Given this list of marker genes REL, IL13, RELB, VAPA, CPEB4, LAT, CREM, PEBP1, MAOB, SFT2D1, NINJ1, GALC, COL9A2, ALS2, ALG13, PTGS1, MAT2A, RASSF5 (NCBI Gene Id 83593), RBM8A, CAPG (NCBI Gene Id 822), DUSP10, CDKN1A, PIGA, SLC18A2, PRNP, MIR4435-2HG, HSPA5, STK17B, SFPQ, OAZ2, SAMSN1, PDCL3, CSF1, OSBPL8, CATSPER1, SYTL2, NSMCE1, VMP1, RPL24, LRP4, MCTP1, MIR202HG, CRBN, TLE3, FCER1A, SCIN, TPSAB1, NME4, LGALS12, CLU, RGS1, ABCA1 (ATP binding cassette subfamily A member 1), VEGFA, SVIP, EIF5A, TNFRSF9, HIF1A, JUND, GADD45B, YWHAE, ANXA7, PRKX, DNAJB14, COX7A1, CTNNBL1, MACIR, HSD17B4, CAVIN2, HLTF (NCBI Gene Id 6596), GLUL, TMEM255B, AHR, PRDX6, UTS2, SRSF7, ZNF511, HPGDS, LMNA, DDX27, PRKCA, ENPP3, ADAM12, MYADM, STX11, DNAJB6, NEDD9, SVOPL (NCBI Gene Id 136306), SKIL, EIF5, HNRNPK, RBMX, TANK, GABPB1-IT1, CYCS, KMT2E, BACE2, LAX1, MRPL33, LMNB1, TESPA1, BHLHE40, EIF4A3, ELL2, ANXA1, SMIM3, SRSF5 (serine and arginine rich splicing factor 5), CD82, HNRNPA0, CLCN3, KLRG1, C17orf107, GCSAML, DNAJB9, HS3ST1, ZBTB32, TSPYL1, PIM3, TNFSF10, EMD, HDC, ABHD17B, COL13A1, TAF7, GPBP1, TNFAIP3, AP1S3, CD63, CYSLTR1 (cysteinyl leukotriene receptor 1), CTNNB1, CFAP36, HEY1, HS6ST1, CKLF, STXBP6, BATF, MLPH, HAX1, MAPK6, HMGN1, SPART, LEO1, SDCBP, DHRS9, PPP1CB, SEPTIN2, MBOAT7, BCL3, RAB34, SELENOM, ST13, RAB37, SPATA13, ACVR1B, CDK15, RNF145, HNRNPH1, NFE2L2, BTN2A2, NDEL1, RGS2, TMEM176B, MITF, DUSP6, C12orf57, ATP6V0A2, NFKBIZ, DEXI, BTK, PLPP1, TPSG1, HNRNPH3, GNA15, CHASERR, HAMP, NDUFA4, RPS6KA5, GBE1, C21orf91, RGS13, PLK3, LAPTM4A, IL18R1, POLR1F, SRGN, GIHCG, GATA1, METTL21A, RPL37A, EMP3, TNIK, ARHGAP18, HSPA9, DLC1, SLC44A1, TRAPPC2B, PAPOLA (poly(A) polymerase alpha), STX3, ENSA, EHD1, CLEC4OP, COL18A1, SWAP70, AREG, SIGLEC8, BMP2K (NCBI Gene Id 55589), SOX4, P2RX1, FDX1, DAD1, SEC22C, NSMCE1-DT, GPR65, CD83, NDST2, ILF2, PLAT, SYPL1, RBBP8, ELF1, H3-3B, BNIP3L, RPL34, NTRK1, MAPRE3 (NCBI Gene Id 22924), CD69, HBP1, PTAFR, IL4R, CD22, TPSB2, LYST, PHF20, UBA7, NR4A2, AP3S1, PKIG, MIR23AHG, TMEM88, CHMP1B, VWA5A, PPP1R15B, U2AF1, DDIT4, SNX5, TGIF1, NR4A1, HECW2-AS1, GABPB1, CYSTM1, CD9, DDAH2, MYO5C, CDC42EP3, TENT5A, PLIN2, NFATC1, SRSF3, LTC4S, EGR1, MORF4L1, SLC43A3 (solute carrier family 43 member 3), FXYD5, TMEM91, SNHG9, COX17, NICOL1, RASGEF1B, HPGD, DYNLT5, SERPINB1, LINC01140, ALOX5, GATA2, CCL2, NDRG2, FAM177A1, ANXA11, LXN, SGK1, HSD17B12, CAVIN1, PRDX1, P2RY14, TMEM233, JUNB, RHOH, PPP3CA, MAP3K8, ARMCX3, ARHGAP29, BCAS2, BABAM2 (NCBI Gene Id 9577), ICAM1, FOSB, FERMT2, IFITM10, LAT2, NFKB1, MAPRE1, SNHG8, SLC26A2, ITM2A, LPCAT2, ADRB2, ARHGDIB, MAST4, ZNF48, GRAP2, CAMLG, EPAS1, SH3KBP1, AP2M1, RPL36AL, MS4A2, ACOT7, TNFRSF4, TP53BP2, MTFR1L, RHOBTB3, STMN1, SIK1, LMO4, HSP90AB1, ASRGL1, MRPL32, ARL2, TPM1, NFKB2, LINC03002, TDRD3, SELENOK, IDS, CRLF2, SRSF2, DBI, ZFP36, XIST, BZW1, GNPTAB, CTR9, RPS4X, PMP22, ANKRD9, IL5RA, BTG2 (NCBI Gene Id 7832), LRRC70, CCNH, MAGED2, RALB, FOXP1, VAT1, CSRNP1, TSEN54, EGR3, PLEKHF2, PRXL2C, TSC22D1, HEXIM1, EIF1AX, EIF1B, FAH, PLAUR, IL1RL1, SYAP1, HNRNPU, MORF4L2, GPAT4, VIM, PAG1, SLC2A3, SLC11A2, GMPR, ANKRD28, RTF2, PTGS2, TRIM63, TPM4, SYTL3, CSF2RB, YWHAZ, HNRNPA2B1, RAB27B, FOSL2 (FOS like 2, AP-1 transcription factor subunit), AGPS, PDCD4, CHPT1, CNRIP1, SIGLEC17P, SRSF6, MEIS2, PROCR, CALB2, ITM2C, RILPL2, MSRA, MAFF, SLC45A3, TIMP3, MARCHF3, SLC1A5, CPM, CSDE1, NMT2, PTMA, MALAT1, KDM6B, RARRES1, NFKBIA, DUSP14, BTG3, SERPINB6, PRG2, DNAJC19, CTSG, SMYD3, NR4A3, PRKAR1A, ANXA4, CD33, HEG1, PNPLA8, SBDS, NDFIP2, HILPDA, ZNF331, DDX3X, SOCS3, ANKRD37, FAM107B, TUBA1A, GALNT6 (NCBI Gene Id 11226), HBS1L, FTH1P3, PDE4A, DYNLT3, SQSTM1, ATG12, SPECC1, KLF6, PDLIM5, PAK1, ALDH1A1, CD44, ID2, TFG, RENBP, PRPSAP2 (NCBI Gene Id 5636), RAB32, SPINT2, PALLD, SOCS2, CLIC1, NFKBIB, KIT, TIPARP, EIF3E, BEX4 (brain expressed X-linked 4), BCL2A1, STARD10, SOCS1, NXT1, FTH1, NTM, UBB, POLR2K, EXOSC8, BIRC3, NFKBID, FER, DNAJA1, DDX5, CDCA7L, ARHGEF6, LIF, RHEX, SERTAD1, ACSL4, WDR45B, ASAH1, TCEAL4, USP53, RHBDD2, PPP1R15A (NCBI Gene Id 23645), ERF, NFE2L3, TSPYL2, CPA3, VPS37B, PIK3R6, SERINC3, KRT19, RBM39, JMJD6, HNRNPA3, MCL1, FUNDC2, TSPAN4, PBX1, HNRNPM, B4GALT5, MLF1, CSTPP1, here is a description of the gene set: species: Homo sapiens Human Gene Set: TRAVAGLINI_LUNG_BASOPHIL_MAST_2_CELL from publication Travaglini KJ, Nabhan AN, Penland L, Sinha R, Gillich A, Sit RV, Chang S, Conley SD, Mori Y, Seita J, Berry GJ, Shrager JB, Metzger RJ, Kuo CS, Neff N, Weissman IL, Quake SR, Krasnow MA (PMID 33208946)